Given this list of marker genes Bcl2a1a, Rras2, Tmem176a, Il4i1, Tle3, Ifi211, Cpne2 (copine II), Car2, Flot1, Nfkbib, Ankrd33b, Ass1, Birc2, Fhod1, Epb41l2, Fkbp5, Lsp1 (lymphocyte specific 1), Atp6v1b2, Tmem131, Cd40, Rogdi, Mkrn1, Gadd45b, M6pr, Il12b, Arhgap22, Prkcd, Ctsz, Slfn2, Riok3, Pim1, Sema7a, Usp32, Apol7c (NCBI Gene Id 73662), Chd7, Adam19, Iscu, Cttnbp2nl, Stat3, Pfkfb3, Ddt, Ndrg1, Myo1g (NCBI Gene Id 353209), Adam11, Pgap2, Ggta1, Id2, Nr4a3, P2rx5, Pirb, Bcl2a1b, Mxd1, Opa1, Ifitm2, Tmem123, Nfkb2, Arl5a, Socs2, Pex13, Kcnk6, Cxcl16, Ppp1r15a, Mt1, Snap23, Esyt2, Zfc3h1, Bhlhe40, Ilrun, Sdc4, Jak1, Traf1, Tbc1d4, Apol10b, Psme2, Batf, Il2rg, Atp2b1, Cstf3, Serpinb9 (NCBI Gene Id 20723), Litaf, Rassf2, Mif4gd, Mthfs, Itga4, Zmynd15, Pnpla8, Junb, Smarce1, Icosl, Il13ra1 (NCBI Gene Id 16164), Nlrc5, Ttc39b, Pde1b, Znrf1, Rnf216, Rap1b, Dnase1l3, Runx3, Mab21l3, Tspan3, Txndc17, Gucd1, Lcp1, Serinc3, Bcl2l14, Cish, Kif21b, Adcy6, Znfx1, Rap2a, Aebp2, Man1a, Nipal1, Srgn, Plek, Ccl22, Cdkn1a, Gpr137b, Marchf5, Ccl17, Eif1, Laptm4b, Marcks, Elp5, Map4, Casp8, Samsn1, Syngr2, Mrps7, Selplg, Muc1 (mucin 1, transmembrane), Ikbkb, Tank, Fnbp1l, Etv6 (NCBI Gene Id 14011), Clic4, Il21r, Sav1, Swap70, Mvp, Btg1, Vcam1, Cxcl9, B2m, Ehd1, Anxa4, Peli1, Stimate, Malt1, Dusp2, Pnrc1, Ifi205, Adam8, Tmem19, H2-DMb2, Mbd2, Rftn1, Synj1, Stat5a, Cd81, Nectin1, Tnip1 (TNFAIP3 interacting protein 1), Cdk12, Tmem176b, Serpina3g, Sri, Cd83, Nfkbia, Arl5c, Tor1aip2 (NCBI Gene Id 98727), Grk3, Lactb, Zfand3, Snn, Tuba1a, Rtn4, Atp1b3, Tbc1d8, Herpud1, Rab8b, Mtmr4, Ppp4r2, Wnk1, Phlpp1 (NCBI Gene Id 98432), Mllt6, Tnfaip3, Spop, Tmem131l, Ccr7, Etnk1, Edf1, Rrad, Tes (NCBI Gene Id 52121), Tspo, Fabp5, Cytip, Trip12, Nup98, Nabp1, Gbp5, Dennd4a, Serpinb1a, Il4ra, Gca, Birc3, Ptpn1, Nfkbie, Relb, Tmbim6, Pcgf5, Ptger4 (prostaglandin E receptor 4 (subtype EP4)), Gramd2b, Strip2, Slc22a15, N4bp2l1, Cd200, Lyst, Irf5, Snx8, Pik3r1, Adap2, Ube2n, Flnb, Icam1, H2az1 (H2A.Z variant histone 1), Casp4, Cxcl10, Adam23, Tspan33 (tetraspanin 33), Zfp217, Plxnc1, Cd69, Kdm2b, Rabgap1l (NCBI Gene Id 98656), Slc8b1, Tmem63b, Arih1, Ccnd2 (NCBI Gene Id 97325), Sdhaf1, Mir155hg, Timd4, Spint2 (NCBI Gene Id 97345), Serpinb6b, Tnip3, Rnf149, Ly75, AA467197, Wsb2, Gypc, Sipa1l3, Csf2rb, Etv3 (NCBI Gene Id 99611), Bcl2a1d, Btla, Cd274, Cd86 (CD86 antigen), Slc33a1, H2-D1, Sult1a1, Aff4, Avpi1, Zfp36l1, Gpr132, Pum2 (pumilio RNA-binding family member 2), Tnfsf9, Cdc37l1, Lpp, Rgs1, Cyria, Smad4, Cacnb3, Bcl3, Clec2d, Glipr2, Rel, Cflar, Lamp1, Kpna3, Basp1, Rnf19b, Fam53b, Oasl1, Ncoa7, Dusp5, Procr, Zfp36, Gclc, Efhd2, Tapbpl, Bcl2l11, Irf1, Marcksl1, Lrrk1, Jak2, Ino80d, Apobec3, Wfdc17, Il15ra, Galnt7, H2-K1, Mcemp1, Gdi1, Poglut1, Il1b, Csrp1, Slc30a4, Sbno1, Prpf38b, Pdcd1lg2, Stxbp3, Fscn1, Cyba, Cacna1s, Foxp4, Nrp2, Slc25a19, Krit1, Gnai3, Rab21, here is a description of the gene set: Cytokines mediate cell-cell communication in the immune system and represent important therapeutic targets. A myriad of studies have highlighted their central role in immune function, yet we lack a global view of the cellular responses of each immune cell type to each cytokine. To address this gap, the authors created the Immune Dictionary, a compendium of single-cell transcriptomic profiles of more than 17 immune cell types in response to each of 86 cytokines (>1,400 cytokine-cell type combinations) in mouse lymph nodes in vivo. A cytokine-centric view of the dictionary revealed that most cytokines induce highly cell-type-specific responses. For example, the inflammatory cytokine interleukin-1β induces distinct gene programmes in almost every cell type. A cell-type-centric view of the dictionary identified more than 66 cytokine-driven cellular polarization states across immune cell types, including previously uncharacterized states such as an interleukin-18-induced polyfunctional natural killer cell state. Genes positively differentially expressed in cell type: cDC1 (conventional dendritic cell type 1) upon treatment with cytokine: TNF-α in mouse lymph nodes in vivo. from publication Cui A, Huang T, Li S, Ma A, Pérez JL, Sander C, Keskin DB, Wu CJ, Fraenkel E, Hacohen N (PMID 38057668) studied in species Mus musculus Mouse Gene Set: CUI_CDC1_TNFA_RESPONSE_UP